Given this list of marker genes Atp1a1, Fxyd1, Ryr2, Ctnna3, Cacna1c, Scn10a (NCBI Gene Id 208230), Ccn2, Cav1, Adrb1, Strit1, Scn5a, Pln, Ace2, Dsg2, Smtn, Gata4, Tnni3, Atp1b1, Kcnq1, Bin1, Calm1, Casq2 (NCBI Gene Id 99894), Rgs2, Adora1, Jup, Hsp90aa1, Hdac4, Atp1a2, Adcy10, Stc1, Pde5a, Calm2, Akap6, Dsc2, Chga, Dmd, Dlg1, Adra1a, Zc3h12a, Calm3, Tmem38b, Atp2a2, Myh7b, Kcnj2, Trpm4, Sumo1, Bmp10, Rangrf, Cav3, Slc8a1, Atp2a1, Akap9, Pde4d, Cacna1h, Gja5 (gap junction protein, alpha 5), Ucn, Fgf13, Sri, Hcn4, Tnni3k, Tmem38a, P2rx4, Pkp2, Agrn, Ank2, Ehd3, Dsp, Fkbp1b, Slc9a1, Rnf207, Smad7, Nkx2-5, Adra1b, Nppa, here is a description of the gene set: studied in species Mus musculus Mouse Gene Set: GOBP_REGULATION_OF_CARDIAC_MUSCLE_CONTRACTION Any process that modulates the frequency, rate or extent of cardiac muscle contraction.